The following is a description of a gene set: species: Homo sapiens Human Gene Set: ZNF236_TARGET_GENES Genes containing one or more binding sites for (ZNF236) in their promoter regions (TSS -1000,+100 bp) as identified by GTRD version 20.06 ChIP-seq harmonization. from publication Yevshin I, Sharipov R, Kolmykov S, Kondrakhin Y, Kolpakov F (PMID 30445619), and this is the list of marker genes: KDM5D, CEP95, KDM3A, FUT8, PPP6R1, SOX14, GPATCH8, DNAH6, STYX (NCBI Gene Id 730432), PCAT6, MSL2, PIGN, CEP57L1, SNX24, POGZ, UBP1, RNF43, HSPA8, MTF2, NEAT1, RELCH, MMAB, MDH1, VAV3, AJUBA, CASP4, EIF4A2, ARHGEF12, CTNNB1 (catenin beta 1), DPH5, FOXJ3, SRP54-AS1, AIG1, LYRM7, MAPK7, LINC02960, PIK3C2B, ZCCHC9, ZFP1, GPALPP1, TSSC4, AATF, SPICE1, SP110, SH3BGRL3, CFAP70, ACTMAP, RABIF, MROH8, NUP58, LRP6, CDKL3, CALM2, PMP22, LEMD1, OR2A13P, FUS, OSBPL10, RNASEK, LLGL2, MCUB, B9D1, EHF, CNTD1, UBB, SYBU-AS1, DDB1, RPS8, RFC1, ENTPD1-AS1, AP1G1, KCTD9, ZWILCH, SMIM14, DNAJB4, MALAT1, MPV17L2, RNF213-AS1, HNRNPD-DT, HNRNPD, HSP90AB1, CLTCL1, TCF12, RPL4 (ribosomal protein L4), PAFAH2, PHKBP1, HEXIM2, PDE4D, EEF1E1-BLOC1S5 (NCBI Gene Id 100526837), EPS8, MIR5188, CDK13, PSMG4, RAD1, RAVER1, PTEN, TMEM134, ABCF2, GIN1, EEF1E1, RBAK, ZKSCAN2, RPS26, SESN1, PHF14, LIN7C, ZNF446, U2AF2, PARPBP, ZNF860, RBM22, GFI1B, TNRC18 (NCBI Gene Id 84629), SMIM13, EDRF1-DT, NUP37, ZNF821, CCNI, POLR1G, NDUFAF1, NEMF, TUBB2B, TSC22D2, DDX50, ATAD2, RPS27L, SNRPA, RFFL, PKM, BRIX1, PNISR, ZNF280D, MEF2A, ALG1, CREB1, UBE2B, ZWINT, ENSG00000266401, DLST, GCA, WDPCP, LRRC57, PCM1, CDC25C, DPH5-DT, CDCA2, HMG20A, OGT, CDC42SE1, STK40, RAB6C-AS1, RNASEK-C17orf49, CDK13-DT, RPL21, INTS13, LINC02983, ZC3H6, NAB2, SLX4IP, IST1 (IST1 factor associated with ESCRT-III), C14orf119 (chromosome 14 open reading frame 119), EIF2B5, ANKRD13C, FAM32A, TSC1, CBR4-DT, ENDOV, B4GALT7, CKMT2-AS1, CLTC (clathrin heavy chain), TRAF4, ZNF518A, PHC3, ATXN2L (ataxin 2 like), COX6C, CFAP20, SPDL1, RBM47, ANAPC7, MIR17HG, ZNF678, ARHGEF28, BAG6, RNY4, POLH, SYAP1, PEAK1, C19orf48P, AGR2, CFAP418, ATXN7L3B, LRPPRC, MTHFD2, DDX5, SAXO2, UBASH3B, SDF2L1, SLC19A2, FAM53C, CALM3, DUSP5-DT (NCBI Gene Id 105378482, DUSP5 divergent transcript), TKFC, RBL1, SNORD46, H2BC9, GABPB2, EFL1, TYRP1, MCCC2, CDC27 (NCBI Gene Id 996), TOB2, GSK3B, STPG2, NEMP1, MKKS, VSNL1, SATB2 (NCBI Gene Id 80104), SRP54, ANKRD13C-DT, DHX40, ACP6, FBXO34, CYP51A1, H3C7, PGGT1B, MVK, PSMA3 (NCBI Gene Id 5684), FOXN2, PSMB7, TNPO1, HEXIM2-AS1, LCLAT1, UBC, AJUBA-DT, COASY, BDNF-AS, HAUS2, RBAK-RBAKDN, KIF22, SYBU, NRDC, DENND2B, LINC02453, PPP1R13L, ZNF335, ZNF219, TSPAN31, ENSG00000237773, RCOR1, NAPA, MCM7, LSG1, AKIP1, UBAP1, MGAT1, HMGA1, OGDH, MRPS28, RPN2, EML2, RN7SL706P, TRIM33, ITPR1, UNC93B1